Given this list of marker genes JUP, CTNNB1 (NCBI Gene Id 1499), CDH24, CDH11, CDH8, CTNNA1 (catenin alpha 1), CTNND1, here is a description of the gene set: studied in species Homo sapiens CDH11 homotypic and heterotypic interactions Human Gene Set: REACTOME_CDH11_HOMOTYPIC_AND_HETEROTYPIC_INTERACTIONS